The following is a description of a gene set: Mouse Gene Set: GOMF_TORC2_COMPLEX_BINDING Binding to a TORC2 complex. species: Mus musculus, and this is the list of marker genes: Nckap1l, Pink1, Rpl23a, Armh4, Sirt6